Given this list of marker genes FGFR2, SHC1, SETD4, PTH, MIR10A, LIPA, HMGA2, ACE, MIR27B, LEF1, here is a description of the gene set: species: Homo sapiens Human Gene Set: GOBP_CELL_PROLIFERATION_IN_BONE_MARROW The multiplication or reproduction of cells, resulting in the expansion of a cell population in the bone marrow.